Given this list of marker genes Ddrgk1, Tnf, Akt1, Cx3cl1, Cx3cr1, here is a description of the gene set: Mouse Gene Set: GOBP_REGULATION_OF_I_KAPPAB_PHOSPHORYLATION Any process that modulates the frequency, rate or extent of I-kappaB phosphorylation. species: Mus musculus